The following is a description of a gene set: studied in species Homo sapiens Genes up-regulated in CD8 T cells: control versus over-expressing TERT. from publication Menzel O, Migliaccio M, Goldstein DR, Dahoun S, Delorenzi M, Rufer N (PMID 16951325) Using CD8+ T lymphocyte clones over-expressing telomerase weinvestigated the molecular mechanisms that regulate T cell proliferation. Transduction and subcloning procedures were performed on CD8 + naive T-cell clones isolated from two different healthy individuals aged between 30 to 35 years (HD1 and HD2). T-cell cloneswere transduced to express hTERT/GFP or GFP alone. HD2 was profiled on U133Plus 2.0 and submitted as a separate GEO series. Human Gene Set: GSE5142_CTRL_VS_HTERT_TRANSDUCED_CD8_TCELL_EARLY_PASSAGE_CLONE_UP, and this is the list of marker genes: SNX9, S100A6, STX6, GRHL1 (NCBI Gene Id 29841), STAT5B (signal transducer and activator of transcription 5B), TEX10, CLK2, PHLPP1, NOD1, RGS2, INF2, P4HTM, FARP1, SKIC8, ARHGEF12, GGNBP2, MSRB3, ANKRD29, LCLAT1, JMY, PTPN13, EVA1B, CST7, DHRS3, PAFAH1B3 (platelet activating factor acetylhydrolase 1b catalytic subunit 3), RAB11FIP2, TRIM41, RABGAP1L, ZNF281, BPNT2, RASA1 (RAS p21 protein activator 1), DDC, LEPROT, AGRN, RAB19, IFNAR2, SERINC3, SS18L2, SNRNP27 (small nuclear ribonucleoprotein U4/U6.U5 subunit 27), SCLY, FRMD4B, ARHGEF3, CLEC16A, CAPN2, RNASE4, VAV2, ACBD5, ACOT7, REPS1, RB1, NCOA3 (NCBI Gene Id 8202), NEIL1, CAPN3, RORA, MXD4, VMP1, GTF2IRD1, KIF16B, PANK1, CD274, YPEL2, CIPC, COX6A1, JPT1, VSIG10, BRD9, AHNAK, RGS1, TMBIM1, CILK1, B4GALNT4, LTBP3, VPS54, ADAMTS6, CSTB, RFESD, CCR6, CD81, CAMK4, MELK, POGLUT2, CBL, TUBGCP4, ITGB1, TDRD7, TUBB2A, GBP7, INPP5F, ACOT2, TMEM18, CYB5A, MYO1F, SLK, SYTL2, SH3BGRL, CD6, HOPX, RASGEF1A, CIBAR1, MGAT5 (alpha-1,6-mannosylglycoprotein 6-beta-N-acetylglucosaminyltransferase), GBP4, KIF20B, S100A4, SOCS2, TTC39B, CYFIP1, ANKRD6, SLC35D1, ZC3H7B, CASP4, RGS16, STX1A, ZFYVE19, COL27A1, PRKCA, RBM10, MTBP, TNFRSF4, GKAP1, FLCN, HIF1A, DEK, IL2RA, PHLDA1, PEAK1, DHX57, EEA1, ARHGAP18, SMC4, KIF5C, ICE1, MYO18A, ZDHHC21, CHRAC1, SLC4A7, TJP2, SHISA5, SEC11C, NCAPG, SAV1, CATSPERD, CD80 (CD80 molecule), SLAMF1, CDIPT, ZDHHC20, ATG4C, YTHDC1, NTN4, PLSCR1, TATDN1, PSMA5, IKZF2, WLS, MYO5A (NCBI Gene Id 4644), DNAJC1, PLAAT3, PCYT1B, STK3, MTMR11, PTGER2, SNW1 (NCBI Gene Id 22938), CAPN15, NUMA1, ESRP2, CNRIP1, STON1, TNP1, ZNF862, FAR1, ZNF827, GNAQ, PRR13, MSH6, SOAT1, RNF157 (ring finger protein 157), WASL, LRRC75A, LARS2, ACSBG1, DDX17, TUBB2B, NSMAF, CYTIP, C9orf152, KANSL1L, C3orf70, PLCB4, ZNF182, EIF2B2, MATN2, ATP6V0D2, APBB1, EBI3, PAQR3, FMNL3, VIM, MYO1C, PLD2, HAUS6, OSGIN1